The following is a description of a gene set: Enables the transmembrane transfer of a sodium ion by a channel that opens when a specific ligand has been bound by the channel complex or one of its constituent parts. species: Mus musculus Mouse Gene Set: GOMF_LIGAND_GATED_SODIUM_CHANNEL_ACTIVITY, and this is the list of marker genes: Scnn1a, Grik1, Tpcn2, Grin1, Asic2, Asic4, Scnn1g, Grik5, Asic5, Grik4, Grik3, Asic1, Tpcn1, Scnn1b, Grik2, Gria2, Asic3